Given this list of marker genes CTTN, NID1, STRIP2, TMEM121B, NTRK1, PCDH9, ETV4, ABCB4, NR4A2, LEF1, GAD1, RGCC, MICAL2, A2M, CD36, LPAR5, PDE4A, TBC1D4, AKAP12, TGM2, ARHGAP6, IL1RAP, ZFP36L1, CD38, CPA3, CA2, AREG, CST7, VCAN, here is a description of the gene set: species: Homo sapiens Acute myeloid leukemia (AML) is a caricature of normal hematopoiesis driven from leukemia stem cells (LSC) that share some hematopoietic stem cell (HSC) programs including responsiveness to inflammatory signaling. Although inflammation dysregulates mature myeloid cells and influences stemness programs and lineage determination in HSCs by activating stress myelopoiesis, such roles in LSCs are poorly understood. Here, we show that S1PR3, a receptor for the bioactive lipid sphingosine-1-phosphate, is a central regulator that drives myeloid differentiation and activates inflammatory programs in both HSCs and LSCs. S1PR3-mediated inflammatory signatures varied in a continuum from primitive to mature myeloid states across cohorts of patients with AML, each with distinct phenotypic and clinical properties. S1PR3 was high in LSCs and blasts of mature myeloid samples with linkages to chemosensitivity, whereas S1PR3 activation in primitive samples promoted LSC differentiation leading to eradication. Our studies open new avenues for therapeutic target identification specific for each AML subset.<BR/>Significance: S1PR3 is a novel regulator of myeloid fate in normal hematopoiesis that is heterogeneously expressed in AML. S1PR3 marks a subset of less primitive AML cases with a distinct inflammatory signature and therefore has clinical implications as both a therapeutic target and a biomarker to distinguish primitive from mature AML. from publication Xie SZ, Kaufmann KB, Wang W, Chan-Seng-Yue M, Gan OI, Laurenti E, Garcia-Prat L, Takayanagi SI, Ng SWK, Xu C, Zeng AGX, Jin L, McLeod J, Wagenblast E, Mitchell A, Kennedy JA, Liu Q, Boutzen H, Kleinau M, Jargstorf J, Holmes G, Zhang Y, Voisin V, Bader GD, Wang JCY, Hannun YA, Luberto C, Schroeder T, Minden MD, Dick JE (PMID 33458693) Human Gene Set: XIE_LT_HSC_S1PR3_OE_UP Genes upregulated in long-term hematopoietic stem cells (CD34+,CD38_,CD45RA_,CD90+,CD49f+) upon overexpression of Sphingosine-1-Phosphate Receptor 3 (S1PR3)